The following is a description of a gene set: from publication Hummerich L, Müller R, Hess J, Kokocinski F, Hahn M, Fürstenberger G, Mauch C, Lichter P, Angel P (PMID 16247483) Chemically induced mouse skin carcinogenesis represents the most extensively utilized animal model to unravel the multistage nature of tumour development and to design novel therapeutic concepts of human epithelial neoplasia. We combined this tumour model with comprehensive gene expression analysis and could identify a large set of novel tumour-associated genes that have not been associated with epithelial skin cancer development yet. Expression data of selected genes were confirmed by semiquantitative and quantitative RT-PCR as well as in situ hybridization and immunofluorescence analysis on mouse tumour sections. Enhanced expression of genes identified in our screen was also demonstrated in mouse keratinocyte cell lines that form tumours in vivo. Self-organizing map clustering was performed to identify different kinetics of gene expression and coregulation during skin cancer progression. Detailed analysis of differential expressed genes according to their functional annotation confirmed the involvement of several biological processes, such as regulation of cell cycle, apoptosis, extracellular proteolysis and cell adhesion, during skin malignancy. Finally, we detected high transcript levels of ANXA1, LCN2 and S100A8 as well as reduced levels for NDR2 protein in human skin tumour specimens demonstrating that tumour-associated genes identified in the chemically induced tumour model might be of great relevance for the understanding of human epithelial malignancies as well. Human Gene Set: HUMMERICH_BENIGN_SKIN_TUMOR_UP Genes up-regulated in benign skin tumors (papilloma) induced by treatment with DMBA and TPA chemicals in the two stage skin carcinogenesis model. studied in species Mus musculus, and this is the list of marker genes: TGM3, FABP5, ZNF205, SERPIND1, TLCD3A, RHOG, GSTO1, KRT13, KRT16, S100A8, S100A9, SLPI, DROSHA, SPRR2D, KLK9, USP25